The following is a description of a gene set: Mouse Gene Set: REACTOME_FRS_MEDIATED_FGFR2_SIGNALING FRS-mediated FGFR2 signaling studied in species Mus musculus, and this is the list of marker genes: Grb2, Fgf8, Ptpn11, Frs2 (NCBI Gene Id 327826), Kras, Fgf20, Frs3, Sos1, Fgf4, Fgf1, Fgf18, Fgf23 (NCBI Gene Id 64654), Fgf10, Fgf7, Fgf22, Fgf17, Fgf9, Fgf2, Fgf6, Fgf16, Hras, Fgf3, Fgf5